The following is a description of a gene set: Mouse Gene Set: GOBP_POSITIVE_REGULATION_OF_LYMPHOCYTE_DIFFERENTIATION studied in species Mus musculus Any process that activates or increases the frequency, rate or extent of lymphocyte differentiation., and this is the list of marker genes: Smarcd2, Nkap, Ambra1, Tnfsf9, Rhoh, Smarcd3, Spi1, Gimap3, Phf10, Pik3r6, Foxp3, Gimap5, Adam8, Tox, Malt1, H2-Ea, Il21, Il4, Il4i1 (NCBI Gene Id 15088), Actl6b, Sox13, Ep300, Xrcc6, Ddrgk1, Il4ra, Lilrb4b, H2-DMa, Flt3l, Runx3, Shh, Ripk2, Irf1, Prkdc, Carmil2, Smarcd1, Smarcb1, Il1rl2, Smarca2, Ihh, Gas6, Ccr7, Pbrm1, Rara, Wnt10b, Shb, Mdk, Zap70, Nfkbiz, H2-Aa (histocompatibility 2, class II antigen A, alpha), Brd7, Stat5a, Syk, Lilrb4a, Ifng, Pnp, Il2ra, Bcl6, Lck, Zfp609, Gli3, Cyld, Il2rg, Cd74, Tgfbr2, Cd1d1, Gata3, Brd2, Il6, Il7, Brd4, Pck1, Rasgrp1 (RAS guanyl releasing protein 1), Ada, Kat5, Smarcc1, Tgfb1, Arid2, Il12a, Anxa1, Axl, Pcid2, Skint1, Ap3b1, Foxo3, Runx1, Rhoa, Stat5b, Vsir, Nfkbid, H2-M3 (NCBI Gene Id 14991), Opa1, Socs5, Xbp1, Il10, Klhl25, Ap3d1, Actl6a, Inpp5d, Sox4, Ccl19, Il15ra (interleukin 15 receptor, alpha chain), Ptprc, Egr3, Smarce1, Sash3, Ccr2, Mir326, Tespa1, Il18, Hlx, Nckap1l, Nlrp3, Il7r, Cd83, Zbtb7b, Hsp90aa1, Lef1, Arid1a, Vnn1, Tnfsf4, Zbtb1, Il2 (interleukin 2), Cd27, Smarcc2, Socs1 (NCBI Gene Id 12703), Il15, Cbfb, Ppp2r3c, Rag1, Zmiz1, Itpkb, Bad, Smarca4, Dusp10, Il23a, Sox12, Il36b, Sart1, Cd46, Btn2a2, Atp11c, Prkcz, Lgals9, Mmp14, Actb